Given this list of marker genes ARRB1, ARRB2, TGFB2, TGFBR2, GIPC1, TGFBR3, TGFB1, TGFBR1, here is a description of the gene set: Reactome Pathway: TGFBR3 regulates TGF-beta signaling This subpathway describes the activation of TGFBR3 by TGF ligands and the subsequent regulation of TGF signaling by TGFBR3 (López‑Casillas et al.,1991,López‑Casillas et al.,1994, Blobe et al.,2001) studied in species Homo sapiens part of: Signaling by TGFBR3